The following is a description of a gene set: 7q11.23 distal copy number variation Human Gene Set: WP_7Q1123_DISTAL_COPY_NUMBER_VARIATION species: Homo sapiens, and this is the list of marker genes: EPB41L3, SNORA14A, KIF1C, PTPMT1, TMEM120A, SFN, LMNA, ZP1, TMEM120B, DAPK2, ZP2, MDH2 (NCBI Gene Id 4191), YWHAG, HSPB1, RAF1, ZP3, SRRM3, G3BP1, STYXL1, RHBDD2, SSC4D, POR